Given this list of marker genes LCN10, HMGB1, TLR3, NR1D1, CEBPA, VSIG4, IL13, MIF, C5AR1, ITGAM, MMP8, STK39, PLA2G4A, CD200, MIR145, PLA2G10, IL4, PLA2G3, SLC11A1, TREM2, TLR4, CD93, BPI, IFNGR2, KARS1, GPR137B, IFNGR1, CX3CR1, MCUB, TREX1, NR4A1, MAPT (NCBI Gene Id 8152), LRFN5, IL10, MIR128-1, CD74, AZU1, IFI35, IGHE, AGER (NCBI Gene Id 177), TNF, JAK2, SUCNR1, STAP1, IL1RL1, SYT11, FCGR2B, MIR130A, MIR181C, TICAM1, MIR142, JMJD6, JUND, GRN, JUN, SHPK, NMI, IL33, IL31RA, THBS1, C1QA, FOXP1, CCL3, WNT5A, HAVCR2, ADGRF5, TNIP2 (TNFAIP3 interacting protein 2), TYROBP, SYK, MFHAS1, TMEM106A, AIF1, TLR6, TMEM229B, FCER2, FCGR3A, PLCG2, HSPD1, CALHM2, IRGM, SPHK1, SNCA, PRKCE, CST7, CTSC (NCBI Gene Id 50958), TAFA3, CRTC3, FPR2, LBP, HSPA12A, CLU, TTBK1 (tau tubulin kinase 1), MYO18A, LDLR, ITGB2, SBNO2, PJA2, KCNJ8, FAM76B, RORA, APP, NR1H3, ZC3H12A, CX3CL1, IL6, TLR1, LRRK2, DYSF, WNK4, PTPRC, SPACA3, IFNG, IL4R, NAGLU, TLR9, EDN2, here is a description of the gene set: Human Gene Set: GOBP_MACROPHAGE_ACTIVATION A change in morphology and behavior of a macrophage resulting from exposure to a cytokine, chemokine, cellular ligand, or soluble factor. species: Homo sapiens